The following is a description of a gene set: The part of the cytoskeleton (the internal framework of a cell) composed of actin and associated proteins. Includes actin cytoskeleton-associated complexes. Mouse Gene Set: GOCC_ACTIN_CYTOSKELETON studied in species Mus musculus, and this is the list of marker genes: Myo19, Micall2 (NCBI Gene Id 231830), Myh15 (NCBI Gene Id 677358), Myh11, Pdxp, Mst1r, Cobl, Actl10, Stk17b, Lcp1, Actr2, Myo16, Acta2, Nexn, Fmn2, Corin, Myl3, Rnd1, Arpc1b, Keap1, Dlc1, Stoml2, Cdc42bpa, Filip1l, Ddr2, Crk, Gbp2, Lmod1, Parva, Actl9, Actn1, Topbp1 (NCBI Gene Id 72768), Dapk1, Ang6, Fchsd1, Tnnc1, Snx9, Cfl1, Acta1, Dnaja3, Msra, Ppp1r12c, Myo15a, Ccn5, Pkd2l1, Arap1, Septin7, Lancl2, Catip (NCBI Gene Id 636180), Mtss2, Pawr, Tns3, Fermt2, Trmt10a, Actn2 (actinin alpha 2), Specc1, Hfe, Mpp4, Tlnrd1, Cdc42ep4, Spef1, Arpc4, Cdh1, Vill, Mtpn, Hax1, Auts2, Tnni2, Lima1, Tnni3, Septin2, Hnrnpc, Fhl3, Gas2, Cdc42ep3, Trip6, Epb41l2, Dyrk1a, Lad1, Kncn, Prickle4, Kif9, Hspb7, Ankrd23 (ankyrin repeat domain 23), Dctn2, Peak1, Capza1, Kntc1, Ncoa5, Lurap1, Myo1b, Myoz2, Limd2, Ocm, Taf5, Dbnl, Tnnc2, Myo5c, Dbn1, Fhdc1 (FH2 domain containing 1), Vps11, Capzb, Dnajc24, Sh3pxd2b, Tek, Dixdc1, Ttc17, Myo5b, Myl9, Csrp1, Fyn, Stx1a, Ppp1r9a, Anln, Ppp1r12b, Wipf1, Gjb6, Plekhh2, Gng12, Twf2, Afap1, Nos1ap, Dctn4, Myo1g, Arhgap21, Shroom4, Svil, Pdlim4, Baiap2, Cap1, Krt19, Sorbs1, Fer, Snap25, Crmp1, Rac2, Tpm1, Actr1a, Tmem63b, Myh4, Sptb, Adam17, Abi2, Flot1, Myo1c, Mark2, Myh2, Myh10, Taok2 (TAO kinase 2), Myl1, Whrn, Pdlim7, Gas2l2, Kansl2, Fscn2, Ndc1, Klhl14, Efr3b, Dctn6, Dusp22, Grhl3, Piezo1, Arpc5l, Hnrnpk, Actr1b, Anxa2, Epha3, Dapk3, Ang4, Myo18b, Rac3, Shld2, Add1, Pjvk, Ntn1, Pls3, Ints6, Ppp1r12a, Actn4, Abra, Cttnbp2, Onecut2, Enah, Arhgef5, Arhgap35, Plec, Cald1, Parvg, Cryab, Bloc1s6, Dctn3, Calb2, Rhou, Stk38l, Clic5, Flt1, Pgm5, Coro1a, Prkcb, Mylk, Cttn, Marcks, Tnni1, Apc2, Vps16, Crocc, Myl4, Aif1, Avil, Arc, Tpm3-rs7, Wasl, Filip1, Spata13, Fgr, Lpxn, Lmod2, Cd2ap, Msrb1, Vcam1, Mical1, Inpp5d, Diaph1, Actrt1, Palld, Ablim2, Was, Dst, Dgkh, Fmn1, Dmtn, Actg1, Evl, Actrt3, Cfl2 (NCBI Gene Id 12632), Myl2, Pak1, Vangl2, Adam8, Ezr (NCBI Gene Id 97496), Mprip, Itpka, Bin3, Asap1, Myo9b, Ahnak, Tspan5, Gas2l3, Rab5a, Capza1b, Rinl, Slc2a1, Fhod1, Cldn5, Jam3, Diaph3, Nf2, Srcin1, Cit, Arpc1a, Myzap, Myl7, Npffr2, Ppp2r3c, Tpm3, Actg2, Mical2, Bmf (BCL2 modifying factor), Rab8a, Myo3b, Gys2, Arpc5, Med28, Myo1e, Pdlim1, Vil1, Rflnb, Tax1bp3, Hip1, Cttnbp2nl, Kptn, Luzp1, Iqgap1, Sipa1l3, Foxa3, Tpm4, Fam107a, Myl6, Ctnna2, Cotl1 (coactosin like F-actin binding protein 1), Cgn, Rab22a, Myl12a, Myh9, Dpysl3, Flnc (filamin C, gamma), Arhgap33, Myh14, Tnnt3, Bin2, Acaca, Sptbn2, Dstn, Atp12a, Coro1b, Pstpip1, Tmsb15b2, D7Ertd443e, Snca, Rdx, Tmsb15l, Yes1, Prkcz, Mlph, Sptbn4, Axl, Misp, Amotl2, Itsn1, Fscn3, Myoz3, Fblim1, Ttn, Diaph2, Sgpp1, Iqcg, Arhgef2, Flnb, Neurl1b, Gbp2b, Myo1f, Ptges3, Lpp, Tagln2, Gmfg, Tfpt, Phldb2, Sh3gl1, Shroom3, Epb41, Aif1l, Myl12b, Sptbn1, Myh1, Mapk8, Lasp1, Ang2, Nckap1, Myrip, Septin5, Myh8, Add2, Synpo, Shroom2, Barx2, Dynll2, Pdlim5, Actl11, Tnnt1, Cnn3, Gdpd2, Ackr2 (atypical chemokine receptor 2), Kat2b, Hdac4, Myo1a, Maea, Sptbn5, Sptan1, Calb1 (calbindin 1), Pvalb, Gsn, Tnnt2, Scin, Arhgap6, Coro2b, Ppp1r9b, Myh7b, Hip1r, Ilk, Pknox2, Myo3a, Fkbp15, Gfral, Scn8a, Cnn1, Npm3, Nup85, Appl1 (adaptor protein, phosphotyrosine interaction, PH domain and leucine zipper containing 1), Ush1g, Myo18a, Afap1l1, Scnn1a, Acte1, Espn (NCBI Gene Id 56226), Cdh2, Synpo2, Akap13, Pxn, Capza3, Rara (NCBI Gene Id 19401), Zyx, Myh6, Myo9a, Septin9, Adcy8, Samd14, Myh7, Myo6, Sh2b2, Lmod3, Arsj, Actr10, Pls1, Cnr1, Cdc42bpb (NCBI Gene Id 93839), Baiap2l1 (BAI1-associated protein 2-like 1), Septin11, Dctn5, Tpm2, Actb, Tmod2, Gmfb, Eef1a1, Ang5, Map2, Ldb3, Llgl2, Mylpf, Specc1l, Hck, Ctnna1, Actr3, Xirp2, Myo1h (NCBI Gene Id 67424), Rapgef3, Arpc3, Rgs22, Amot, Spry2, Rigi (RNA sensor RIG-I), Spta1, Dhx9, Ophn1, Myl6b, Myoz1, Anxa1, Gabarap, Myadm, Gas2l1, Mtss1 (NCBI Gene Id 70087), Aldoa, Dnm2, Carmil2, Bpifb4, Capg, Abl1, Bcar1, Myo7a (NCBI Gene Id 17921), Actn3, Fermt3 (NCBI Gene Id 98150), Ptk2, Sh3pxd2a, Myo1d, Asb2, Carmil1, Rac1, Ptpn12, Tmod1 (tropomodulin 1), Daam1, Flot2, Flna, Tmod4, Ptpn11, Ang, Twf1, Sipa1l1, Cd274 (CD274 antigen), Hcls1, Lrrc7, Nebl, Pdlim2, Macf1 (microtubule-actin crosslinking factor 1), Ablim1, Sppl2b, Erc1, Tsc1, Myo7b, Mylk3, Actrt2, Myo5a (myosin VA), Cenpq, Xirp1, Arpc2, Klhl2, Map3k1, Neb (NCBI Gene Id 99028), Ablim3, Apbb3, Flii, Rtkn, Piezo2, Cgnl1, Trpv4, Cluap1, Llgl1, Abl2, Pdcd6ip, Klhl17, Tagln3, Capza2 (NCBI Gene Id 76913), Ccdc102a, Limch1, Myh13, Tmc2, Ror1, Cnn2, Synpo2l, H1f0, Myh3, Fhod3, Rflna, Vps18, Rhoq, Fscn1, Vcl, Dock5, Dennd2a, Wdr1, Src, Triobp, Coro1c, Tmod3, Cib2, Gas7, Arhgap32, Cyba, Pof1b, Gck, Swap70, Actbl2, Actc1, Myo10, Jup, Pdlim3 (PDZ and LIM domain 3), Nox4, Shroom1 (NCBI Gene Id 71774), Ankrd26, Rai14, Parvb